The following is a description of a gene set: Human Gene Set: MIR548AV_5P_MIR548K Genes predicted to be targets of miRBase v22 microRNA hsa-miR-548av-5p, hsa-miR-548k in miRDB v6.0 with MirTarget v4 prediction scores > 80 (high confidence targets). from publication Chen Y, Wang X (PMID 31504780) studied in species Homo sapiens, and this is the list of marker genes: SERTAD2, SINHCAF, KLHL3, PPP3CB, PPP3CA, TAF12, IGF2BP3, GUCY1A2, TAB3, ZNF789, RHOQ (ras homolog family member Q), DSCC1, CDK6, TMEM229A, TTC17, PTBP3, ERICH2, ITGAV, IVNS1ABP, ROBO1, PROSER1, ZNF711, EPC1, CNTN5, ZNF611, SPCS2, CEP350, SOS2, ANKDD1B, HTR2C, RNF138, KLHL28, AAK1, AR, BCLAF3, MID2, SPON1, NR1I2, PPHLN1, GJB7, APPBP2, PRR23A, MTCP1, ZEB2, NECTIN1, EIF5A2, TANC1, KMT5B, POU2F1, FIGN, DMRT2, SEMA6D, ACSL4, ZNF680, MMUT, CD164, TLX3, GSPT2, WNK3, SPDL1, LY75, MEF2C, UCK2, SRSF6, RAB11A, PRELID1, ITGA9, GRIP1, CPNE4, ZBTB41, C1D, GSTM2, PI4K2B, YTHDF1, FNIP2, DNAJB4, PDZRN4, MTF1, OPRK1, SATB2, PTAR1, BNIP3 (NCBI Gene Id 664), ANKRD11, PDZRN3, AFG3L2, ABHD3, ZNF281, CBLB, VEZF1, ZNF800, ENC1, TMEM156, SCML2, GPATCH2L, PREX2, TGFBR1, BICD1, CCNL1, C5orf15, DAP, STEAP2, CPNE2, ATOSA, KLF8, RAP1A, TRIM43B, RRM2B, CD47, HYCC1, FNDC3B, ARID4B, MAP3K2, RPGR, PAXIP1, ARHGEF38, PPP6C, SAR1B, MFSD14A, CISD2, ORC3, PDS5B, CTNND1 (NCBI Gene Id 82168), LMBR1, NUP153, ZNF26, FAM13C, MGAT4A, PDZD8, MARCHF6, GOPC, CNTN1, FUBP1, FAM168B, OCIAD2, CSNK1D, FEM1C, NAPB, ZNF493, VPS4B, FMR1, GMNC, DMXL2, IL23A, MCOLN3, KLHL13, ADAMTS6, RBM18, GULP1, EIF2AK3, CD109, REEP3, LIN7C, ACAT2, ATRX, LSM8, ATXN1L, CD55, IGFL1, SLC24A3, VPS26C, HYOU1, UBE2A, UBE2B, LRP2, TBC1D3B, TWF1 (twinfilin actin binding protein 1), TOP2A, YWHAZ, WDR11 (NCBI Gene Id 79207), BEND4, HS2ST1, NPAP1, TENT4B (NCBI Gene Id 64282), ANKRD22, ZNF600, PDK1, TP53TG3C, SUMO1, SNTB1, PTPRM, MLH3, SPTLC2, LGI1, HECA, NCAPG2, KCTD18, CACNA2D3, P2RY10, GDA, NCKAP1, MIER3, YWHAQ, MAP3K7CL, RSRC2, RUFY3, CELF5, CUL4A, SLC35A1, TNC, TCP1 (NCBI Gene Id 6950), RAB9B (RAB9B, member RAS oncogene family), PTMA (NCBI Gene Id 91418), MAP9, MEF2A, TRIM43, UGT2B17, GLIPR2, SORBS2, ZNF486 (NCBI Gene Id 90649), NCOR1, C5orf24, SLC5A3, SS18, KLF10, CCNY, LRP12, PTPN12, MSN, KCNK2 (potassium two pore domain channel subfamily K member 2), LCORL, TRIP11, OTUD4, RNF111, ZIC1, SLC9A6, HDAC4, PSPH, POGLUT2, RASGRP1, MEX3D, ANGPTL5, GPATCH11, DDX5, GPM6A, WDR77, ANXA2, FKBP7, MYCN, SCARB2, GOLPH3, A1CF, STXBP5, IKZF5, SERINC5, PKN2 (NCBI Gene Id 5586), EFNA5, ZBTB44, MED6 (mediator complex subunit 6), CXADR, ADAMTS1 (NCBI Gene Id 9510), REPS2, BCL10, ELAVL4, SMG1, BBX, SKIL, DSP, TCEAL8, PDE1A, P4HB, ST8SIA1 (ST8 alpha-N-acetyl-neuraminide alpha-2,8-sialyltransferase 1), WNT5A, PLEKHG1, BRD1, NFAT5, THSD7A, SAMD8, KITLG, RNF148, MYBL1, BPNT2, GOLT1B, ZDHHC17, RAB6B, CARF, CYP1B1, PNN, TM9SF3, SERPINB3, SH3RF3, KRAS, MAP4K5, SMOC2, FMNL2, NEGR1, CDK19, KAT6A, TMEM100, WWP2, ABCC4, DDIAS, NFE2L2, FBXO43, TADA1, FAM120A, LPCAT2, RUNX2, SH2D1A, NOTCH1, CEP120, TBCA, CNN3, CCSER2, AP1G1, MEX3B, ADAM22, NEDD4L